Given this list of marker genes G6PC3, GP1BA, TFRC, WDR1, WAS (NCBI Gene Id 7454), here is a description of the gene set: studied in species Homo sapiens Intermittent thrombocytopenia Reduced platelet count that occurs sporadically, i.e., it comes and goes. Human Gene Set: HP_INTERMITTENT_THROMBOCYTOPENIA